Given this list of marker genes TCF7L2, ZFYVE28, CAPN3, RNF149, ADIRF, CCDC180, DICER1-AS1, CHST12, TBATA, RTP4, DCAF4, PTPRF, GBP5, PPP1R11, FANCA, TMED9, UFM1, HLA-DPA1, BTN3A1, KCNMB1, C3orf70, CDH9, MDGA1, CENPA, HLA-A, APOL2, PSME2, NLRC5, HYAL3, C12orf42, CFAP161 (cilia and flagella associated protein 161), USP42, FAM219A, TYW5 (tRNA-yW synthesizing protein 5), GIMAP8, SLC7A13, RSAD2, KCNB2, LINC00839, IFRD1, CARD16, MYCN, EIF1, CHD5, CARD6, DYNC1H1, INHBA, CFAP46, RAB4B, CASP1 (caspase 1), UPB1, SAMD9L, DNAJC1, OR7E36P, DYNLT1, MYO1E, PLAAT4, DMRTB1, TRIM56, RBCK1, PSMB4, TICAM1, IQCH, SOAT1, CCL20, SCARF1, ZRANB2, CDK12, GRIN3A, MUC17, FSTL5, NIFK-AS1, TTPAL, PLAUR, UBE2L6, UBXN4, LINC02145, SECTM1, TAP1, HLA-DRB6, LRRC4C, VPS9D1, C15orf39 (chromosome 15 open reading frame 39), IL23A, PSMB10, FAP, ACTG1P17, RCL1, ALDH5A1, CLVS1, AMN1, BNIP1, CMTR1, CAVIN3, STARD4, HLA-DOB, ARHGAP15, PRKCZ, CCDC32, MRPS18A, ARHGEF3, POC1B, RALA, MOBP, RUNX3 (RUNX family transcription factor 3), PLEKHO1, SH3BP5, ULBP2, PCDHB6, CD74, GLS, ADRB2, HELZ2, PAX8, FCGR1A (NCBI Gene Id 50698), TUBA4B, ZNRF2P1, EVA1C, PTK7, DDX60L, WARS1, HNRNPA1L2, D2HGDH, LRRC52-AS1, CREB5, GBP1, KCNJ8, HLA-DPB1, TRIM21, ADM, MFSD2A, HMGA2, BCAT1, DECR1, GMPPA, TAFA5, LINC00851, MICB, TLNRD1, HCAR3, C19orf12, CACNA2D1, RGPD4-AS1, GRHL3, DUSP5 (NCBI Gene Id 1847), IL20, ZNF385C, RBM43, CALHM6, CEP170B, PELO, SRSF1, HLA-DRB1, CSF2, GRAP2, MTHFD2L, RGS7, UBR4, TLE6, IRAK1, TNF (NCBI Gene Id 7124), STAT2 (signal transducer and activator of transcription 2), MYDGF, NEBL, ADAM30, SERPINB2, BAALC, KHNYN, PSMB9, RIGI, STAT1, PMS2P5, TECTB, NFAT5, PPP2R2A (NCBI Gene Id 5520), GIMAP6, HIVEP2, EREG, PRPF3, STARD8 (NCBI Gene Id 9754), SLC39A11, DTL, IL12RB1, SH3BP2, SND1, BANP, KARS1, AUNIP, here is a description of the gene set: Effects of Neuromedin-U on gene expression in mouse D10.G4.1 T-cells natively expressing the GPCR Axor13 studied in species Homo sapiens Human Gene Set: GSE1791_CTRL_VS_NEUROMEDINU_IN_T_CELL_LINE_3H_UP from publication Johnson EN, Appelbaum ER, Carpenter DC, Cox RF, Disa J, Foley JJ, Ghosh SK, Naselsky DP, Pullen MA, Sarau HM, Scheff SR, Steplewski KM, Zaks-Zilberman M, Aiyar N (PMID 15585845) Genes up-regulated in D10.G4.1 T cell line (3h): control versus treated with NMU.